Given this list of marker genes Rack1, Prdx3, Rps6ka3, Serpinb9d, Casp8ap2, Serpinb9f, Bcl2a1d, Atp2a3, Naip2, Tnfaip8 (NCBI Gene Id 106869), Cd27, Serpinb9h, Bcl10, Nkx3-1, Gas6, Birc7, Ngf, Casp8, Apaf1, Bad, Tnfrsf10b, Serpinb9b, Naip5, Vil1, Serpinb9c, Naip1, Naip6, Rps6ka1, Tnfsf14, Serpinb9g, Serpinb9e, Nol3, Prdx5, Foxl2, Mapk9, Rps27l, Avp, Birc3, Birc2, Birc5, Bcl2l1, Serpinb9, Xiap, Snca, Dpep1, Ctsh, here is a description of the gene set: species: Mus musculus Mouse Gene Set: GOMF_CYSTEINE_TYPE_ENDOPEPTIDASE_REGULATOR_ACTIVITY_INVOLVED_IN_APOPTOTIC_PROCESS Binds to and modulates the activity of a cysteine-type endopeptidase involved in the apoptotic process.